Given this list of marker genes TYK2, CYBB, ZNFX1, NUPR1, PPP2R5A, FKBPL, ELAVL4, CREBRF, ANXA1, CTTNBP2NL, SEC13, TMEM192, FASTKD5, COG8, RALGDS, KMT5A, VCAN, PXMP2, NEAT1 (NCBI Gene Id 283131), TPR (translocated promoter region, nuclear basket protein), ESD, BAZ1B, PSENEN, GMPPB, ARF4, ASB3, ZFAND2A, UBE2M, DDX4, APPBP2, TPRKB, TTC28 (tetratricopeptide repeat domain 28), KCNMA1, SLC28A2, PDE6D, EPSTI1, STARD3NL, PEF1, GDE1, PLAGL2, TRIP12, UNC119B, CEP350, TXNL1, TJAP1 (tight junction associated protein 1), ZNF841, MPZL2, HMGA1, MTMR14, CXCR5, GFPT2, CLK3, ADNP, SPA17, ITGA4, ARHGAP35, TRIM25, SLC6A4, P2RY12, SNHG8, ANGPT1, NCOA3, PLEKHA3, VPS72, KAT2B, LUC7L3, FLCN, CD70, TUBG2, UBE2R2, CD47, GINM1, TRAF5, GBP2 (guanylate binding protein 2), CTTN, MITD1, CDIP1, SNX2, ME1 (NCBI Gene Id 4199), KATNBL1, BIRC3, DHX8, RASSF3, C1orf54, NKD2, RARG, GBP4, IFNAR2, HOMER1, GALNT6, GRIK5, GFRA4, ZNF436, NECTIN2, SPTLC2, BLOC1S6, MUC1, DOCK6, CCNE1, NXPH1, TMEM179B, FTL (NCBI Gene Id 93315), KTN1, NEU1, NIPSNAP3A, BHMT2, CCNT2, FRMD8, CCL5, RHPN2, RNF167, DSPP, NMUR1, SH3TC1, PHF13, RPS6KB2, TMEM185A, GPBP1L1, ENKD1, PPP1R15B, DNAJB1, OLR1, CPT1A, PPP1CB, SPEG, SLC35A5, FABP3, NGEF, CAMK2D, IREB2, TMEM38B, SQSTM1, SYNE2, GTF2E2, PI4K2A, DDA1, LHX2, CACYBP, TDRD7, SSTR1, FBXW11, FBXO11, BNIP2, H2AC25, NAE1, SNX10, WFS1, KREMEN1, F11R, TNFSF9, ZEB2, WASHC4, SERPINB9, PSMA4, KHDC4, USP47, MX2, RIPK2, DUSP26, SMARCAD1, ATG12, GOSR1, SLC6A8, WASF2, TSPYL1, SPO11, PKP4, TBK1, VCL, PRR14, HCAR2, VPS54, STAU1, TDRD3, SLC2A5 (solute carrier family 2 member 5), FOXI1, RBP3, MS4A6A, GSPT1, RAB38, PLEKHF2, ATP13A1, BFAR, RNF34, BCKDHB, KLRK1, PHLDB1, BCL10, GCA, CHMP1B, DLGAP4, ILF3, DTX2, MCL1, PLXNB3, ALPK2, C6orf62, SYF2, CMTM6, CALCR (NCBI Gene Id 799), here is a description of the gene set: from publication Amit I, Garber M, Chevrier N, Leite AP, Donner Y, Eisenhaure T, Guttman M, Grenier JK, Li W, Zuk O, Schubert LA, Birditt B, Shay T, Goren A, Zhang X, Smith Z, Deering R, McDonald RC, Cabili M, Bernstein BE, Rinn JL, Meissner A, Root DE, Hacohen N, Regev A (PMID 19729616) studied in species Homo sapiens mouse primary BMDCs were stimulated with tlr ligands and gene expression changes were profiled on Affymetrix arrays Human Gene Set: GSE17721_0.5H_VS_12H_POLYIC_BMDC_DN Genes down-regulated in comparison of dendritic cells (DC) stimulated with poly(I:C) (TLR3 agonist) at 0.5 h versus those stimulated at 4 h.